The following is a description of a gene set: Human Gene Set: TSUNODA_CISPLATIN_RESISTANCE_UP Genes up-regulated in bladder cancer cells resistant to cisplatin compared to the parental cells sensitive to the drug. species: Homo sapiens To investigate the molecules that regulate the acquisition of cis-diamminedichloroplatinum (II) (cisplatin) resistance, we performed cDNA microarrays using two pairs of parental and cisplatin-resistant bladder cancer cell lines. We found a markedly reduced expression of inositol 1,4,5-trisphosphate (IP3) receptor type1 (IP3R1), endoplasmic reticulum membrane protein, in cisplatin-resistant cells. The suppression of IP3R1 expression using small interfering RNA in parental cells prevented apoptosis and resulted in decreased sensitivity to cisplatin. Contrarily, overexpression of IP3R1 in resistant cells induced apoptosis and increased sensitivity to cisplatin. These results suggest that cisplatin-induced downregulation of IP3R1 expression was closely associated with the acquisition of cisplatin resistance in bladder cancer cells. from publication Tsunoda T, Koga H, Yokomizo A, Tatsugami K, Eto M, Inokuchi J, Hirata A, Masuda K, Okumura K, Naito S (PMID 15608674), and this is the list of marker genes: CCN1, G0S2 (G0/G1 switch 2), EFEMP1, NT5E, C1S, ARHGDIB, UCA1, IFI27, VAV3, CCN2, PLAU, DIO2, BRAP, INSIG1, VIM